The following is a description of a gene set: Human Gene Set: chr8q24 species: Homo sapiens, and this is the list of marker genes: MFSD3, LNCOC1, GPR20, HGH1, LINC02878, ENSG00000253407, TOP1MT, MROH1, ZNHIT1P1, ZNF707, LINC02964, ENSG00000253433, DPPA3P7, WASHC5, PEG13, FAM83A-AS2, AK3P2, TG, ENSG00000212342, FAM83H, KHDRBS3, ENSG00000253593, TMEM276, LY6D, FER1L6-AS2 (NCBI Gene Id 157376), SMPD5, TONSL-AS1, ENSG00000287201, SNTB1, PYCR3, DENND3-AS1, ZNF517, ATAD2, LINC02055, CCDC166, SCRIB, EEF1D, RN7SL260P, RN7SKP155, ZNF572, LINC00964, ENSG00000287325, RNA5SP278, MIR1302-7, HMGB1P19, CDK5P1, ASAP1, RNU6-628P, UTP23, RNU6-12P, NAPRT, GRINA, POU5F1B, ZHX2, GPAA1, PLEC, SLA, MTRF1LP2 (NCBI Gene Id 100130376), RNU6-1255P, MIR151A, MIR4472-1, RHPN1-AS1, MIR3610, TMEM249, ST3GAL1-DT, ZFAT-AS1, MIR6845, MAF1 (MAF1 homolog, negative regulator of RNA polymerase III), ENSG00000308109, RN7SL395P, OPLAH, C8orf76, UBA52P5, ENSG00000238901, MROH4P, MIR939, MIR4662A, ENSG00000254278, MIR30B, MAL2, NDUFB9, MIR3686, FER1L6, PTP4A3, ARHGAP39, LINC01300 (NCBI Gene Id 731779), MIR6846, PCAT1, ZNF623, TONSL, WDR97, ZNF252P, HSF1, SMILR, PTK2, RHPN1 (NCBI Gene Id 114822), ZHX1, DUTP2, RN7SL228P, DERL1, ADGRB1, EPPK1, MIR1234, MTSS1, ENSG00000294187, JRK, ZNF252P-AS1, CASC11, TBC1D31, ENSG00000221461, LY6S, SLC45A4-AS1 (SLC45A4 antisense RNA 1), ENSG00000253607, LYPD2, ENSG00000253165, MIR4663, ENSG00000308533, TATDN1, TMEM71, ST3GAL1, ZFTRAF1, FER1L6-AS1, MRPL13, CCDC26, KNOP1P5, COMMD5, TMED10P1, ZNF696, ENSG00000286535, RN7SL329P, MRS2P1 (MRS2 pseudogene 1), MTCO1P49, ERICD, RECQL4, ASAP1-IT2, SLC30A8, LYNX1-SLURP2 (LYNX1-SLURP2 readthrough), GSDMD, IQANK1, HPYR1, ZC3H3, MIR1204, C8orf17, SCRT1, AARD, SPATC1, DSCC1, MYC, ENSG00000255491, ENSG00000289161, RPL32P20, LINC01151, THEM6, LINC01591, RNU6-875P, MTBP (NCBI Gene Id 27085), SAMD12, MROH6, LY6S-AS1, MIR4664, RPL21P78 (NCBI Gene Id 100271185), RN7SKP153, HAS2-AS1, SLC45A4, GFUS, RN7SKP226, MIR7112, ZNF34, RFPL4AP5, MIR4662B, RPL23AP56, PRNCR1, MIR30D, ENSG00000253470 (novel transcript), ST13P6, DEPTOR-AS1, CYC1, FAM83A, MAFA-AS1, LRRC14, EXOSC4, ARF1P3, CCN3, ZNF250 (NCBI Gene Id 58500), ANXA13, LINC03024, RAD21-AS1, ENSG00000206776, KLHL38, ENSG00000302188, HNRNPA1P38, WASHC5-AS1, OC90, RPS10P16, CPSF1, CYRIB, SLURP1, RNU6-144P, MIR1206, ENSG00000214803, NRBP2, ADCY8, ENSG00000307854, ZNF16, LINC00824 (long intergenic non-protein coding RNA 824), C8orf33, LRRC24, MIR548AZ, RPL15P12, ENSG00000238854, IADEN, RNF139-DT, MAL2-AS1, LY6K, TRMT12, PUF60, RPS26P35, LINC02912, HHLA1, ZNF7, MIR1205, ZNF251, ENSG00000253574, RN7SL396P, CHRAC1, PHF20L1, MIR6844, CCAT2, RPL35AP19, LINC00861, GPIHBP1, RNU6-442P (NCBI Gene Id 106479761), PSCA, TMEM276-ZFTRAF1, KIFC2, C8orf90, EFR3A, RN7SL826P, TIGD5, CYCSP23, NTAQ1, TAF2, CASC8, TRAPPC9, CCN4, ENSG00000286010, COLEC10, SQLE, ENSG00000305490, EIF3H, ADCK5, ZYXP1, FAM83A-AS1, LYNX1, IMPDH1P6, TRIB1AL, MIR661, SQLE-DT, ENSG00000248318 (novel transcript), MAPRE1P1, TSSK5P, ARC, EXT1, ZFP41, TNFRSF11B, MTND2P7, GSDMC, FAM135B, SHARPIN, GML, MED30, MIR6850, CASC19, LY6E-DT, LY6H, C8orf82, CYP11B2, SNORA72, FAM91A1, ENSG00000272384, MINCR, RNU4-25P, VPS28 (NCBI Gene Id 51160), GPT, FOXH1, FBXO32, SCX, ASTILCS, RN7SKP206, RNU7-181P, DGAT1, ENPP2, ENSG00000244791, DENND3, SAMD12-AS1, PVT1, ENSG00000306504, MIR6893, RAD21, MIR6847, TSNARE1, LRATD2 (LRAT domain containing 2), MRPS36P3, RPL8, MIR5194, MAPK15, COL22A1, TRIB1, ENSG00000294265, MIR1207, AGO2, RNVU1-32, FBXL6, GLI4 (GLI family zinc finger 4), PPP1R16A, BOP1, MIR6849, MAFA, LINC00051, PARP10, CYP11B1, MROH5, COL14A1, ZHX1-C8orf76, MIR7848, RNF139 (NCBI Gene Id 11236), RNU6-869P, NSMCE2, DNAJC8P3, MIR548D1, NDRG1, DEPTOR, KCNK9, SLC52A2, HAS2, RN7SKP175, SLURP2, MIR6848, ENSG00000212273, SOD1P3, MIR1208, CDC42P3, KCNQ3, RNU11-4P, ENSG00000310521, MIR937 (NCBI Gene Id 100126338), LY6E, LINC02855, RNU6-756P (NCBI Gene Id 106479900), DNAAF11, SLC39A4, LY6L, NCAPGP1, RNU6-220P, ZFAT, MIR548AA1, RNU1-35P, RNA5SP277, TMEM65, PTCSC1, ENSG00000300805